Given this list of marker genes FARS2, SDHAF1, FBXO28, GCSH, ATAD3A, NGLY1, SDHD, NDUFB7, GFM2, SLC25A12, PSAP (NCBI Gene Id 83009), GRM7, NAT8L, CNP, NFU1, SLC35A2 (NCBI Gene Id 7355), TBCK, SV2A, FOCAD (NCBI Gene Id 54914), CACNA1G, ASPA, GALC, here is a description of the gene set: Human Gene Set: HP_ABNORMAL_BRAIN_N_ACETYL_ASPARTATE_LEVEL_BY_MRS Abnormal brain N-acetyl aspartate level by MRS studied in species Homo sapiens A deviation from normal in the level of N-acetyl aspartate in the brain identified by magnetic resonance spectroscopy (MRS).